Given this list of marker genes Gmps, Ada, Ampd2, Ampd1, Adss2, Nmnat2 (nicotinamide nucleotide adenylyltransferase 2), Adss1, Dck, Uck2, Adk, Impdh1, Ampd3, Nmrk1, Upp2, Impdh2, Dguok, Nmrk2, Upp1, Aprt, Naprt, Nmnat1, Hprt1 (NCBI Gene Id 97612), Gmpr, Nampt, Nmnat3, Adsl, Uckl1, Slc25a51, Uck1, Nadsyn1, Pnp, Cda, Gmpr2, here is a description of the gene set: Any process which produces a nucleotide, a compound consisting of a nucleoside that is esterified with (ortho)phosphate or an oligophosphate at any hydroxyl group on the glycose moiety, from derivatives of it without de novo synthesis. species: Mus musculus Mouse Gene Set: GOBP_NUCLEOTIDE_SALVAGE